The following is a description of a gene set: from publication Ben-Porath I, Thomson MW, Carey VJ, Ge R, Bell GW, Regev A, Weinberg RA (PMID 18443585) Cancer cells possess traits reminiscent of those ascribed to normal stem cells. It is unclear, however, whether these phenotypic similarities reflect the activity of common molecular pathways. Here, we analyze the enrichment patterns of gene sets associated with embryonic stem (ES) cell identity in the expression profiles of various human tumor types. We find that histologically poorly differentiated tumors show preferential overexpression of genes normally enriched in ES cells, combined with preferential repression of Polycomb-regulated genes. Moreover, activation targets of Nanog, Oct4, Sox2 and c-Myc are more frequently overexpressed in poorly differentiated tumors than in well-differentiated tumors. In breast cancers, this ES-like signature is associated with high-grade estrogen receptor (ER)-negative tumors, often of the basal-like subtype, and with poor clinical outcome. The ES signature is also present in poorly differentiated glioblastomas and bladder carcinomas. We identify a subset of ES cell-associated transcription regulators that are highly expressed in poorly differentiated tumors. Our results reveal a previously unknown link between genes associated with ES cell identity and the histopathological traits of tumors and support the possibility that these genes contribute to stem cell-like phenotypes shown by many tumors. species: Homo sapiens Human Gene Set: BENPORATH_ES_CORE_NINE Set 'Core 9': 'embryonic stem cell' transcription regulators that are preferentially and coordinately overexpressed in the high-grade, ER-negative breast cancer tumors., and this is the list of marker genes: NFE2L3, TCF7L1, HMGB3, ZIC1, MYBL2, KLF5, ILF3, HMGA1, TEAD4